The following is a description of a gene set: species: Mus musculus Abacavir ADME Mouse Gene Set: REACTOME_ABACAVIR_ADME, and this is the list of marker genes: Nt5c2, Slc22a1, Adal, Slc22a3, Slc22a2, Adh1